Given this list of marker genes Frs2, Grb2, Fgf2, Fgf4, Fgf17, Fgf6, Fgf16, Rps27a, Fgf15, Mapk3, Spry2, Fgf1, Fgf20, Ubb, Klb, Cbl, Fgf23 (fibroblast growth factor 23), Fgf8, here is a description of the gene set: studied in species Mus musculus Reactome Pathway: Negative regulation of FGFR4 signaling part of: Signaling by FGFR4 electronically inferred by orthology from the curated human pathway This event has been computationally inferred from an event that has been demonstrated in another species.<p>The inference is based on the homology mapping from PANTHER. Briefly, reactions for which all involved PhysicalEntities (in input, output and catalyst) have a mapped orthologue/paralogue (for complexes at least 75% of components must have a mapping) are inferred to the other species.